The following is a description of a gene set: Genes predicted to be targets of miRBase v22 microRNA mmu_miR_328_3p, mmu_miR_6395 in miRDB v6.0 with MirTarget v4 prediction scores > 80 (high confidence targets). Mouse Gene Set: MIR_328_3P_MIR_6395 from publication Chen Y, Wang X (PMID 31504780) species: Mus musculus, and this is the list of marker genes: Prss8, Lrtm2, Barhl1, Snph, Pgm2, Myo19, Dync1i1, Prdm16, Ttc16, Plod2, Igf1r, H2ax, Ubfd1, Ulk2 (unc-51 like kinase 2), As3mt, Drd1, Fzd7, B4galnt1, Tcf7l2, Casq1, Nkx3-1, Kirrel3, Kcna7, Lgr4, Cnr1, Rbfox1